The following is a description of a gene set: The chemical reactions and pathways involving low-density lipoprotein receptors. studied in species Mus musculus Mouse Gene Set: GOBP_LOW_DENSITY_LIPOPROTEIN_RECEPTOR_PARTICLE_METABOLIC_PROCESS, and this is the list of marker genes: Apoe, Furin, Anxa2, Mylip, Abca2, Pcsk9